Given this list of marker genes SHH, HHAT, PIK3R1, AKT1, GAS1, DHH (NCBI Gene Id 791256), GRK2, PTCH1, STIL, PIK3CA, GLI2, CDON, IHH, LRPAP1, TGFB2, PTHLH, HHIP, SMO, ARRB2, LRP2, PTCH2, BOC, here is a description of the gene set: Human Gene Set: PID_HEDGEHOG_2PATHWAY species: Homo sapiens Signaling events mediated by the Hedgehog family from publication Schaefer CF, Anthony K, Krupa S, Buchoff J, Day M, Hannay T, Buetow KH (PMID 18832364)